Given this list of marker genes LDHD, MTX2, TIMM23, CHCHD7 (coiled-coil-helix-coiled-coil-helix domain containing 7), NDUFB8, SAMM50, TOMM5, ATP5MC1, TAFAZZIN, CMC4, HSCB (NCBI Gene Id 150274), TOMM40, DNAJC19, TIMM44, SLC25A6, ATP5F1A, COA6, TOMM6, HSPD1, CHCHD5, TIMM13, PMPCB, PMPCA, CMC2, GRPEL2, TIMM10B (translocase of inner mitochondrial membrane 10B), HSPA9, TIMM50 (NCBI Gene Id 92609), TOMM7, PAM16, OTC, CHCHD4, CHCHD2, TIMM22, TIMM17B, SLC25A4, CS, COQ2, ATP5F1B, SLC25A13, VDAC1 (NCBI Gene Id 7416), GFER, PITRM1, COX17, SLC25A12, MTX1, CYC1, CHCHD10, COX19, TIMM9, BCS1L, TIMM10, TOMM20, CHCHD3, TIMM8B, COA4, TIMM8A, FXN, IDH3G, ACO2, GRPEL1, TOMM70, TIMM17A, TOMM22, TIMM21, here is a description of the gene set: Human Gene Set: REACTOME_MITOCHONDRIAL_PROTEIN_IMPORT Mitochondrial protein import species: Homo sapiens